Given this list of marker genes KANSL1, PKP4, RNF150, ARHGAP5, TOX3, USP24, ARHGAP24, RORA, CGNL1, OSBPL3, TRIM2, CALCR, PTH2R, RBM25, ITPR1, CA10, ADAMTS9-AS2, LRBA, CNNM2, DYNC2H1, BTBD9, DST, ERBB4, LGR4, INPP4B, WNK1, COBLL1, ABLIM1, ICA1, FAF1, ATP9B, MAPK8, CACNA1D, APBB2, MACROD2, VAV3, KIAA1958, ZNF518A, PTPN4, PDE10A, ADGRL2, WSB1, TRPM7, PTPRG, LRP1B, CDK14, TBL1X, FNDC3B, TMEM52B, ATXN1 (NCBI Gene Id 7912), TCF12, GPHN, TNRC6B, AHI1, AGAP1, NCOA1, ACSL4, ABCA5, PARD3B, KNG1, NOS1AP, PPP2R3A, AK3, LRCH1, RABGAP1L, ME3, IL1RAPL2, TSC22D2, SLC12A3, DACH1, SAMD12, PTGER3, KLHL13, CAMKMT, GRB14, CCDC148, OPHN1, RAD51B, KLHL3, VWA8, PKHD1, SVIL, CTDSPL, MAP4K3, CA12, COMMD10, NAV2 (NCBI Gene Id 89797), DANT2, SNX29, LINC00970, DNAH14, KANK1, MSI2, HIBCH, NEDD4L, ANKRD26, SLC8A1 (NCBI Gene Id 6546), CRADD, MITF, NHS, TMEM161B-DT, ADAMTS17, NR2F2-AS1, WDFY2 (NCBI Gene Id 115825), FRMD3, SCAPER, WDR72, SH3RF1, EGF, THRB, TEX41, EXOC4, XIST, FTX (NCBI Gene Id 100302692), EFNA5, KLF12, TRAPPC9, FMN1, KCNJ16, RHOBTB3, FGF13, MEF2A, QKI, CADM1, ESRRG, PLPPR1 (phospholipid phosphatase related 1), IMMP2L, LIMCH1, JPX, RERE, CACNB4, TRPM6, UBR3, CCSER1, TNRC6A, LINC00645, CBLB, MAN1A1 (mannosidase alpha class 1A member 1), ARB2A, SKAP1, EXOC6B, ANK3, FAAH2, SAMD5, BICC1, FGD4, FHOD3, FHIT, GPC5, KCNIP4, PCCA, TAPT1-AS1 (TAPT1 antisense RNA 1 (head to head)), ABCA10, MBD5, UBA6-DT, SOX6, PDE8A, ATP1B1 (ATPase Na+/K+ transporting subunit beta 1), GMDS-DT, WWOX (NCBI Gene Id 9621), SNHG14, HDAC8, FBXL17, SHROOM3, BCAS3, NAALADL2, AGBL4, TACC1, ZNF385D, SIK3, CASR, FRAS1 (NCBI Gene Id 84949), LRMDA, NFE2L2, BRAF, PIK3C2G, PLCL1 (NCBI Gene Id 5334), VPS13B, USP25, COL4A3, SCN2A, FREM1, DPH6, SMYD3, PPARGC1A, MTR, AUH, NR3C2, ZNF704, CCDC198, DNAAF9, SBF2, KIAA1217, CPEB4, IVNS1ABP, CLASP1, PNISR, MECOM, OXR1, ARHGAP6, TBC1D5, CDKAL1, RALGAPA1, DCDC2, RNPC3, CADPS2, CACNA2D3, MAML2, here is a description of the gene set: from publication Lake BB, Chen S, Hoshi M, Plongthongkum N, Salamon D, Knoten A, Vijayan A, Venkatesh R, Kim EH, Gao D, Gaut J, Zhang K, Jain S (PMID 31249312) studied in species Homo sapiens Human Gene Set: LAKE_ADULT_KIDNEY_C14_DISTAL_CONVOLUTED_TUBULE